The following is a description of a gene set: Mouse Gene Set: GOBP_NEGATIVE_REGULATION_OF_INSULIN_SECRETION_INVOLVED_IN_CELLULAR_RESPONSE_TO_GLUCOSE_STIMULUS Any process that decreases the frequency, rate or extent of the regulated release of insulin that contributes to the response of a cell to glucose. studied in species Mus musculus, and this is the list of marker genes: Klf7 (NCBI Gene Id 93691), Pim3, Crhr2, Mup4, Adra2a, Mup3, Fkbp1b, Pde3b (phosphodiesterase 3B, cGMP-inhibited), Tbc1d1, Eny2, Ucp2, Mup1, Hmgcr, Pde4c, Ndufaf2, Ptpmt1, Mup2, Mup5, Pde8b, Pde1c, Jagn1, Map4k4, Mup11